Given this list of marker genes FEM1B, KLHDC3, CUL2, FEM1C, RBX1, KLHDC2, CUL4A, DCAF12, KLHDC1, KLHDC10, TRPC4AP, FEM1A (fem-1 homolog A), here is a description of the gene set: The chemical reactions and pathways resulting in the breakdown of a protein or peptide covalently tagged with ubiquitin, via the DesCEND (destruction via C-end degron) pathway. In the DesCEND pathway, C-terminal residues (C-end degrons) in substrates are recognized by Cul2-RING and Cul4-RING E3 ligases, whereupon the substrates are linked to ubiquitin and then delivered to the proteasome for degradation. C-end degrons can be present in full-length proteins, truncated proteins or proteolytically cleaved forms. Human Gene Set: GOBP_UBIQUITIN_DEPENDENT_PROTEIN_CATABOLIC_PROCESS_VIA_THE_C_END_DEGRON_RULE_PATHWAY studied in species Homo sapiens